The following is a description of a gene set: Oxidative damage response Human Gene Set: WP_OXIDATIVE_DAMAGE_RESPONSE studied in species Homo sapiens, and this is the list of marker genes: NFKBIE, BAG4, C5, CDKN1B, CDKN1C (cyclin dependent kinase inhibitor 1C), TRAF2, C3AR1, BCL2, C2, MAP3K9 (mitogen-activated protein kinase kinase kinase 9), APAF1, CASP3, CDC42, BAD, MAP2K4, TNFRSF1B, MAP3K1, TRAF6, BAK1, TDP2, C1QA, MAPK10, MAPK13, PCNA, CYCS (NCBI Gene Id 54205), CR2, NFKB1, C5AR1, CDKN1A, TRAF3, C1QB, C1R, GADD45A, C4B, TNK2, TRAF1 (NCBI Gene Id 7185), C1S, TNF, CASP9, C1QC